Given this list of marker genes NR1H4, FBN1, GHRL, GHSR, NPY, here is a description of the gene set: Human Gene Set: GOBP_POSITIVE_REGULATION_OF_RESPONSE_TO_NUTRIENT_LEVELS studied in species Homo sapiens Any process that activates or increases the frequency, rate or extent of a response to nutrient levels.